Given this list of marker genes LRP6, TCOF1, UBB, WNT10B, EDA, TGFA, IRF6, RUNX2, POLR1D, FGFR1 (fibroblast growth factor receptor 1), WNT10A, EDARADD, POLR1C, SUMO1, POLR1B, GRHL3, AXIN2, PAX9, MSX1, here is a description of the gene set: species: Homo sapiens Human Gene Set: HP_SHORT_FACE Facial height (length) is more than two standard deviations below the mean (objective); or an apparent decrease in the height (length) of the face (subjective). Short face